The following is a description of a gene set: Human Gene Set: NMYC_01 Genes having at least one occurrence of the motif NNCCACGTGNNN in the regions spanning 4 kb centered on their transcription starting sites. This matches the MYCN transcription factor binding site V$NMYC_01 (v7.4 TRANSFAC). studied in species Homo sapiens, and this is the list of marker genes: EIF4B, ALX4, FGF6, FKBP10, ALDH18A1, SLC12A5, GPD1, FGF11, GTPBP1, MGME1, MTHFD1, E2F8, DLX1, BATF3, FBXL19-AS1, SEMA7A, AKAP10, PABPC4 (poly(A) binding protein cytoplasmic 4), WEE1, RAB30, ATP6V0B (ATPase H+ transporting V0 subunit b), UBXN1, USP2, FOXO3, SEMA3F, TOGARAM1, SEZ6L, TESK2, GCSH, MXD4, HYAL2, ENPP6, POGK, CLCN2, INO80, MAX, B4GALT2, IQGAP2, ARMC6, OSR1, RIDA, DCUN1D4, KRTCAP2, NKX2-2, ANGPT2, NOP56, JADE1, SGTB, BEND4 (BEN domain containing 4), NXPH1, HSPE1, ETV1, COL2A1, KCNK5, PRKCE, RCOR2, HSPA9, RPL13A, ZNF296, VWA2, RTN4RL2, FLT3, L1CAM, CHST11, ZFP91, CHRM1 (NCBI Gene Id 92150), BARHL1, PSEN2, SNCAIP, NRXN1, PLAG1, RPIA, NEFM, VGF, CACNA1D, AMPD2, MNT, SLC20A1, RAMP2, SOCS5, HS3ST3A1 (NCBI Gene Id 9955), ARF6, ADPRHL1, POLR3E, KANSL1L, KDM3A, CIART, DNMT3A, POLR3A, CTIF, IPO13, CELF1, KAT6A, FBL, CA14, LHX9, AEN, RNF43, ELOVL6, PA2G4, NRAS, TOP1, UBA1, YBX1, DUSP4, PES1, MAP7, MCM8, RBBP6, HMGN2, NPM1, KLF10, ARRDC3 (arrestin domain containing 3), ATAD3B, ADSS2, GPC3, GNA13, SFXN2, HOXC13, VPS16, TET2, ST6GAL1, LAP3, CNST, CTSF, GIT1, PHF20, MYCL, HHIP, ADAM10, TIMM9, WBP2, MFHAS1, POU3F1, SCFD2, RHBDD3, XRN2, FOXJ3 (NCBI Gene Id 22887), PANK3, RUNX2, SLC17A2, TIMM10, RSPO2, PPARGC1B, RPUSD4, LMNB1, IL1RAPL1, SYNRG, PDIA2, ZZZ3, BCL7C, PRMT1, PCDHA10, TRMT2A, DCHS1, ADAMTS17, TAFA4, RAB2A, TMEM132E-DT, JPH1, KICS2, GJA1, ZHX2, GRK6, C9orf85, ASS1, METTL13, FHOD1, SOX12, SLC43A1, PFN1 (profilin 1), LPCAT4, NR1D1, SPINK5, STMN4, DERL3, ATAD3A, PFKFB3, PABPC1, PRR7, ZCCHC7, KLF11, EPB41, ZMYM6, TEF, VARS2, GRIN2A, PRDX4 (NCBI Gene Id 82852), B3GALT2 (beta-1,3-galactosyltransferase 2), HPCA, SC5D, MAPKAPK3, ABHD17B, RXRB, USP34, U2AF2, CCDC6, HBP1 (NCBI Gene Id 26959), TMED10, RAD9A, SRP72 (signal recognition particle 72), POGLUT1, VPS50, ARHGAP20, RCL1, ADGRB2, HRH3, CTBP2, MAEL, CEBPB, UBR4, ESYT1, GADD45G, ATOSB, CMTM8, LIN28A, KLHL28, RNF128, COPS7A, ASPHD1, EN2, DNAJB9 (NCBI Gene Id 4189), CCDC191, SCYL1 (NCBI Gene Id 57410), PRKCG, PPAT, SLC9A5, EIF3J, ATXN7L2, IGF2BP1, HSPD1, NUP153, GADD45B (growth arrest and DNA damage inducible beta), SLC25A33, PLAGL1, SEPTIN3, NR5A1, APOA5, HOXB7, ADCY3, TLE3, NEUROD6, CAMKV, CDC14A, ATP5MC1, IPO4, ZNF565, TPM2, BMP2K, RBM3, PDK2, EIF4G1, KIAA0586, BCL2, ABCA1, TXLNG, SCRT2, MON1A, NEUROD2, NDUFS1, DLC1, LIG3, HMOX1, PLA2G4A, GPS1, ANXA6, UTP18, MIA2, G6PC3, MINK1, SYBU, WWP2, TIAL1, SH3KBP1, DCTPP1, LRRC59, STAT3, SLC38A5, RPL22, FKBP5